Given this list of marker genes SLC22A4, ZDHHC23, CREB3L3, H4C6, MEX3B, CDCA3 (cell division cycle associated 3), CLK4, KCNA1, SMURF1, LINC-PINT, DSG1, RGS2, SPC24, NFKB2, FOSB, MS4A15, CHEK1, TKTL2, EMILIN1, MYO5C, GRB7, ATP6V1B1, C16orf46, NAMPT, PINLYP, PAGE5, HAPSTR1 (HUWE1 associated protein modifying stress responses), TMEM115, FABP7, ZNF549 (zinc finger protein 549), DPY19L2P2, DNAJC7 (NCBI Gene Id 7266), PALMD, PDE11A, IGLV4-3, SLC25A38, REEP6, CDC42EP3, MDK, RRAD, BNIP1, FAM9A, UGT1A6, TMEM72-AS1, GSTM5, PELI1, ALG12, PLOD2, SPMIP1, MPZL1, FOXO1, SNHG8, SVOP, STK17B, ELMOD3, ZNF777, IRS2, DNAJB1, PATL1, WDR76, EFNB2, AGAP2, CLK1, LINC00305, GEM, SLC9B1, GADD45A, ARMH1, CSHL1, OSM, RBM33, ZNF143-AS1, DNM2 (NCBI Gene Id 338330), DNAJC27, RND1, TMEM44, SHD, NRXN2, IPMK, BCL7B, TIPARP, TWIST1, ZNF165, GADD45B, ADCY2, AKAP10, OTOGL, MIR3142HG, TTLL5, PYDC1, LARP1B, SOX1, FAM30A, MT1M, HDHD5-AS1, CFAP54, C1QL1, MAP3K8, ANKS1B, KCTD5, S1PR3 (sphingosine-1-phosphate receptor 3), TP53BP2, FAM83D, B3GNT9, TGIF2, LINC02112, CAPN11, OSER1, BAZ2A, REXO5, H3C1, FMO3, EML5, ANKUB1, MFAP4, HTN3, ADNP2, MOCS1, PMAIP1, FGF9, ADGRL4, NPC1L1, NEMP2, KIAA1958 (KIAA1958), SPACA3, DUBR, SCN11A, TGIF1, GNL3LP1, NR4A2, FRS2, SNCG, ALKBH1, APOA4, INE1, KRT73, PTGS2, OSR2 (odd-skipped related transciption factor 2), ECRG4, MYRFL, MSL2, SLC25A47 (solute carrier family 25 member 47), MRGPRX2, CDH18, PPP3CC, ZBTB2, HUS1B, ZNF267, MYEF2, SAP30L-AS1, CYP4F11, DUS3L, HCAR3, NIPA1, CLDN10, TRAF1, KRT3, FUT9, CSRNP1, SERPINE1, GPR26, FBXO34, FAM200A, ZBTB43, HNRNPA3P1, SFTA2, CFAP61, XAGE3, CCDC144BP, KDM6B, ZRANB1, C11orf96, PCF11, ZNF846, TSPAN7, SENP2, COA1, MUC5B, PDRG1, PDE4B, COL14A1, CT83, TMEM212, FNBP4, here is a description of the gene set: Human Gene Set: GSE18791_CTRL_VS_NEWCASTLE_VIRUS_DC_1H_DN Genes down-regulated in comparison of control conventional dendritic cells (cDC) at 0 h versus cDCs infected with Newcastle disease virus (NDV) at 1 h. species: Homo sapiens from publication Zaslavsky E, Hershberg U, Seto J, Pham AM, Marquez S, Duke JL, Wetmur JG, Tenoever BR, Sealfon SC, Kleinstein SH (PMID 20164420) The dendritic cell (DC) is a master regulator of immune responses. Pathogenic viruses subvert normal immune function in DCs through the expression of immune antagonists. Understanding how these antagonists interact with the host immune system requires knowledge of the underlying genetic regulatory network that operates during an uninhibited antiviral response. In order to isolate and identify this network, we studied DCs infected with Newcastle Disease Virus (NDV), which is able to stimulate innate immunity and DC maturation through activation of RIG-I signaling, but lacks the ability to evade the human interferon response. To analyze this experimental model, we developed a new approach integrating genome-wide expression kinetics and time-dependent promoter analysis. We found that the genetic program underlying the antiviral cell state transition during the first 18-hours post-infection could be explained by a single regulatory network. Gene expression changes were driven by a step-wise multi-factor cascading control mechanism, where the specific transcription factors controlling expression changed over time. Within this network, most individual genes are regulated by multiple factors, indicating robustness against virus-encoded immune evasion genes. In addition to effectively recapitulating current biological knowledge, we predicted, and validated experimentally, antiviral roles for several novel transcription factors. More generally, our results show how a genetic program can be temporally controlled through a single regulatory network to achieve the large-scale genetic reprogramming characteristic of cell state transitions.